Given this list of marker genes PRKX, PRKACB, ADCY3, PRKAR1B, ADCY7, ADCY4, ADCY5, ADCY2, CREB1, PRKACG (protein kinase cAMP-activated catalytic subunit gamma), NBEA, PRKAR2A, CALM1, ADCY6 (NCBI Gene Id 23320), PRKACA, ADCY8, PRKAR2B, PRKAR1A, ADCY9, ADCY1, here is a description of the gene set: Human Gene Set: REACTOME_PKA_MEDIATED_PHOSPHORYLATION_OF_CREB studied in species Homo sapiens PKA-mediated phosphorylation of CREB